The following is a description of a gene set: Mouse Gene Set: MIR_1983 species: Mus musculus from publication Chen Y, Wang X (PMID 31504780) Genes predicted to be targets of miRBase v22 microRNA mmu_miR_1983 in miRDB v6.0 with MirTarget v4 prediction scores > 80 (high confidence targets)., and this is the list of marker genes: Mapk9, Mthfsd, Ift57, Polr3g, Igsf9, Pou3f4, Ppt1, Tmprss13, Hipk3, Slfn9, Abca5, Nufip1, Hif1an, Snx12, Zfp764, Sv2b, Impa2, Poc1b, Uncx, Rab8b, Rab39b, Hmox2, Arrdc3, Hnf4g, Lyn, Clock, Seh1l, Ube2d2a, Osbpl7, Otud7b, Srsf2, Tmem178b, Cmtm4, Shank2, Zfp516, Fxn, Ifnlr1, Spty2d1, Nfatc3, Hnrnpll, Inafm2, Gpd2, Prb1b, Khdc1b, Rims2, Ehd3, Usp7, Ppp6r3, Wtap, Chst1, Katnbl1, Bach1